The following is a description of a gene set: Mouse Gene Set: GOBP_KYNURENINE_METABOLIC_PROCESS The chemical reactions and pathways involving kynurenine, the amino acid 3-(2-aminobenzoyl)-alanine. species: Mus musculus, and this is the list of marker genes: Aadat, Kyat3, Kmo, Kyat1, Kynu, Ido1, Aldh8a1, Tdo2, Ido2, Afmid